The following is a description of a gene set: Wasting of the tongue. studied in species Homo sapiens Human Gene Set: HP_TONGUE_ATROPHY Tongue atrophy, and this is the list of marker genes: GLT8D1, SPTLC1, ERBB4, PANK2, TARDBP, NEFL (NCBI Gene Id 4747), GLE1, SOD1, IGHMBP2, CFAP410, CHCHD10, CCNF, FRG1, SBF2, PFN1 (profilin 1), DOK7, PON2, PRPH, ANXA11, ANG, NOP56, CHMP2B, MATR3 (matrin 3), TREM2, MORC2, VCP, NEK1, PABPN1, TAF15, SH3TC2, DAO, FIG4, HNRNPA1, EXOSC3, UNC13A, TBK1, GSN, OPTN, VAPB, PPARGC1A, ECEL1, UBQLN2, MUSK, PON3, ATXN2, SLC52A3, PON1, DCTN1, SQSTM1, KY, NEFH, FUS